Given this list of marker genes Ranbp2, Nsmce2, Eid3, Nsmce3, Ube2i, Nscme3l, Pparg, Smc5, Rangap1, Hmga1, Nsmce1, Nsmce4a, Smc6, here is a description of the gene set: Mouse Gene Set: GOCC_SUMO_LIGASE_COMPLEX species: Mus musculus A protein ligase complex that enables protein sumoylation. Consists of a SUMO-protein transferase and other proteins that may confer substrate specificity of the complex.